The following is a description of a gene set: from publication Nagar M, Jacob-Hirsch J, Vernitsky H, Berkun Y, Ben-Horin S, Amariglio N, Bank I, Kloog Y, Rechavi G, Goldstein I (PMID 20181891) studied in species Homo sapiens Human Gene Set: GSE18893_TCONV_VS_TREG_24H_CULTURE_DN Here we show that tumor necrosis factor (TNF) induced in human T-regulatory cells (Treg), as compared to conventional T cells (Tcon), a transcription program highly enriched for typical NF-κB target genes, such as: the cytokines LTA and TNF; the TNF-receptor super family members FAS, 4-1BB and OX-40; various anti-apoptotic genes; and other important immune-response genes. As an initial approach to examine the cellular program induced by TNF in Tregs versus Tcon cells, we employed microarray gene expression analysis at 2 and 24 hrs following TNF treatment. Genes down-regulated in lymphocytes treated with medium for 24h: T conv versus T reg cells., and this is the list of marker genes: IFIT3, CNR2, HAUS8, LY6E, MX1, CD93, RGS13, DBF4, BCL7A, GPRASP3, STING1, FOXO1, DMPK, ARL6, NCAPH, SLC43A3 (solute carrier family 43 member 3), CCP110, ELOVL6, ADAM17, SLC15A3, CD1D, OASL, CENPF (centromere protein F), MYB, MPP1, TMEM64, AKAP12, EGR3, ARMCX3, CERK, NSMF, IFIT1B, KLHL14, TAF5, MMS22L, CDK6, LPCAT2, DLL1, PDE2A, WNT10A, SH2B2, ETS2, PTK2B, FGF13, LEPROTL1, LPAR6, CBLB, TIMELESS, TREM1, TOP2A, ASAH2, IFI44, HIVEP3, MAP7, LCK, LGMN, NFKBID, VAV3, POLR3GL (RNA polymerase III subunit GL), LRIG2, CSRP2, EZH2 (NCBI Gene Id 392834), ARHGAP25, PSAT1, IL4I1, BTLA, ABCA1, TANC2, NCAPG2, TMEM26, SKA1, PAPOLG, NUF2, IFIH1, SHCBP1, SERINC5, TRIP13, MEGF9, FBXW10, RELB, RAPGEF4, SCAF11, PCP4, CASP7, TRPS1, TESK2, CHEK1, CYSLTR1, ZRANB3, PLA2G4A, ITGB3, DCLK2, SMIM3, IRAG2, MX2, GAB3, SPC25, UBE2H, RBBP8, RNF157, CA2, SLC30A4, SRPK3, SUFU, IFI44L, PIK3R3, BEX1, IL21R, CALCOCO1, DHX58, EPB41L2, CCR7, GADD45A, KMO, CMPK2, MCOLN3, CD72, BHLHE40, EDARADD, RIN3, CPM, CFP, TSPAN5, DUSP6 (dual specificity phosphatase 6), VPREB3, FRAT2, CCNG2, ZNF608, SATB1, RASGEF1B, ASB2 (NCBI Gene Id 51676), TCEAL8, SSBP2, STRBP, PLEKHM1, PLXND1, BACH2, N4BP2, RABL3, STAT1, FCRL1, ATP8A1, TRIP4, SDC4, SMARCA5, EMID1, NIBAN3, IFIT2, FANCB, CEP55, TIFA, PLEKHO1, TLR1, IRF7, BCL9, GRAP2, CDCA3, SPDL1, ANKRD50, FCER2, CENPE, BUB1, PBX1, ZFTA, GPAT3, CENPA, CERS6, CD36, BMAL1, FAM241A, LRRK2, INPP5F (NCBI Gene Id 22876), IL12A, SAPCD1, TSPAN3, PNRC1 (proline rich nuclear receptor coactivator 1), ETV5, BCL3, INPP1, SARAF, DMWD, AURKB, RAPGEF5, HDAC1, SPNS2, CFLAR, ARMCX4, LDLRAD3, ZNF513, RNF213, EIF4E3, IGLC7, BCL6, SORL1, NCK2, SLAMF6, MTMR2, BMPR2, IAH1, TRIB2